The following is a description of a gene set: Any process that activates or increases the frequency, rate or extent of the chemical reactions and pathways resulting in the formation of hormones. Human Gene Set: GOBP_POSITIVE_REGULATION_OF_HORMONE_BIOSYNTHETIC_PROCESS studied in species Homo sapiens, and this is the list of marker genes: NR5A2, BMP6, ARNT, DAB2, EGR1, ADM (NCBI Gene Id 133), WNT4, HIF1A, POR